The following is a description of a gene set: The chemical reactions and pathways involving norepinephrine, a hormone secreted by the adrenal medulla, and a neurotransmitter in the sympathetic peripheral nervous system and in some tracts in the central nervous system. It is also the demethylated biosynthetic precursor of epinephrine. Human Gene Set: GOBP_NOREPINEPHRINE_METABOLIC_PROCESS species: Homo sapiens, and this is the list of marker genes: SLITRK1, HAND2, EPAS1, SULT1A3, GATA3, RNF180, PRKN, SULT1A4, ATP7A, DBH, MOXD2P, EDNRA, COMT, RTL4, MOXD1, KL, INSM1, TH